The following is a description of a gene set: Human Gene Set: AHR_Q5 species: Homo sapiens Genes having at least one occurrence of the motif NTNGCGTGNNN in the regions spanning 4 kb centered on their transcription starting sites. This matches the AHR transcription factor binding site V$AHR_Q5 (v7.4 TRANSFAC)., and this is the list of marker genes: CAMK2D, ZNF451, MECP2, TNKS2, ADGRL1, BRSK2, AJUBA, ATL1, NR2F2, WDR33, DTX1, TSPYL2, SLC9A5, DHX40, LHFPL4, SORCS3, GAD2, TRIM23, BZW2, CNOT9, ATG12, MEIS1, MOSPD2, PAQR4, PAGR1, GRIN2B, CACNG3, BCL9L (NCBI Gene Id 283149), EPO, ATOH1, NDUFA13, TEX264, NEUROG2, ARL3, EPHB1, PCNT, EDEM3, SRRM4, VLDLR, TBX5, POU2F1, EYA3 (EYA transcriptional coactivator and phosphatase 3), DOC2A, H2AZ1, MBD3, SUPT16H, CYP1A1 (NCBI Gene Id 1543), MAX, STAC2, INTS13, PHAF1, FOSB, RBBP7, RNF123, SLITRK1, CD320, BCL11B, EID1, ZMYM2, RALGAPB, ZFP91, BIN1, PSMA5, YWHAZ, ASIC1, RUNX1, EIF4A2, HOXC6, DOT1L, CDKN1B, SEC14L1, PIK3R3, KANSL1L, HNRNPDL, AMPD2, INSIG1, MAF, VEGFA, PRKAR2A, IMMT, ZNF521, MLLT10, PTCHD1, PDS5A, ANP32A (NCBI Gene Id 8125), MAZ, SF1, LMO3, ZNF827 (zinc finger protein 827), CBX6 (chromobox 6), IKZF5, ABCB6, PTGES3, SMG6, CYP1B1, PDZD4, ONECUT1, FHOD1, L1CAM, RBM4B, ACADSB, C16orf87, NRGN, BHLHE41, RTN4, HOXC4, REL, AGFG2, SNX14, SRR, RBPJ, MEIS2, CHRM1 (cholinergic receptor muscarinic 1), PPFIA2, DNAAF1, ZNF428, KDM2A, MRPL45, FUT8, ELAVL4, USP37, C21orf58, GIT2, BCL11A, REV3L, RAB6A, TCTA, FAM78A, USP4, TTC9C, FGD1, FANCB, NR0B1, MINK1, STARD10, B3GALNT1, PCBP2, BTBD3, MST1, LENG8, MIDEAS, GADD45G, PTF1A, SERP1, CREBZF, SRSF6, ASPH, AXIN2, WAC, NPHP4, RAVER1, ZBTB25, TUBG1, RAB33A, THAP7-AS1, ASIC2, EIF3A (NCBI Gene Id 8661), NR3C1, PRDM13, DSTN, ZEB1, RHOA, LUM, CFL1, PANK3, KICS2, CIRBP, CHCHD1, DAZAP1 (NCBI Gene Id 26528), FGFR1OP2, PTMA, ADO (2-aminoethanethiol dioxygenase), TAMM41, MNT, ZCCHC14, AP3S1, SPIB, EED, PRDX4, PSD, PALB2, NRG1, ASCL1, SNX12, CDK16, PPP2R2B, ABI2, LCOR, FOXO3, URB1-AS1, HNRNPL, SFXN2, IRF2BPL, GJD2, DCTN5, ZIC2, CNPY2, STAG1, NEK8, RETREG3, FGF9, PITPNC1, ING3, MEX3B, SET, BDNF (brain derived neurotrophic factor), SSBP4, RAB10, NRF1, DDIT3, VAPB, TSSK6, CACUL1, PALS1, HSDL1, FBXO36 (NCBI Gene Id 130888), CACNA1B, SPINT2, TRAPPC13, CMIP (c-Maf inducing protein), ARRB2